Given this list of marker genes PPIF, PDGFA, KRT10, EZR, NPM3, EIF3K (NCBI Gene Id 55373), OASL (NCBI Gene Id 8638), P2RX4, IL1B, NFKB1, PRKRA, ARID5A, HOMER2, CEMIP, CSNK1D, MARCKSL1, MACF1, SLC12A2, CRIP2, CREM, MAPKAPK2, RBM4, SRSF2, VWA8, CRK, PNP, HMOX1, SERPINE1, YWHAZ, TUBB4A, TGFBI, UPP1, EEF1B2, CCL4, LGALS1, DNAJB1, CKS2, UAP1, DUSP5, EMP3, CD69, SEC24D, CD163, IFI44, THBS1, PSMC4, HMGA1 (NCBI Gene Id 3159), PPP1R15A, CLIC1, SRSF3, RPLP0, EIF4E2, CDKN1A, PXDC1, SP100, ZC3HAV1, SLC7A5, HNRNPL, BMPR2, PHLDB1, F13A1, CDC42, IL1RAP, RPN2, CCL3, SLC2A3, SLC16A7, MX1, TP53BP2, HEG1, MXRA7, SSR4, AGO2, MSC, TRAF1, LCP2, LMNA, PTPN2, SRF, IFIT3, NCOR2, COMT, FADS2, MRC1, IVNS1ABP, FUS, PLCG1, PCYT1A, S100A4, SAFB, CDC37, TICAM1, BCAT1, ATF3, DUSP4, ASGR2, TEX30, ICE1, MAP2K3, RGS1, ARNT2, CYP1A1, S100A9, TSC22D3, HINT1, RAB31, USP12, RHOB, SERPINB8, STIP1, CD83, PHLDA2, RPS4Y1, TUBB2A, ICAM1, HSP90AB1, RBMS1, PDE4DIP, ZNF263, NPC1, BCL3, DDIT4, DNM1, ELK4, BTG2, G0S2 (NCBI Gene Id 50486), SERPINB9, SH3BP5, ANPEP, EIF4H (NCBI Gene Id 94573), DEFB1, IL3RA, CXCL2, CXCL1, TNFSF14, ZFP36, CRIP1, POLG, CD99, CD86, CKAP4, RPL35, TXNRD1, ITM2A, XBP1, CLK1, DNAJB5, SP110, CAPN2, CCL7, HNRNPA3, SH3GL1 (NCBI Gene Id 8179), TIPARP, PPP3R1, PIM1, MIR22HG, PRDM1, ATP13A3, S100A8, RUNX3, GDI2, CXCL8, HSPA1A, RPL10A, GEM, TRIM25, LIMK2, CHN2, LAMTOR5, EMP1, CD4, PLTP, FLOT1 (flotillin 1), STAB1, BIN1, MANF, EIF3I, DHX15, SFPQ, EIF4A3, GNA15, P2RY6, SERPINB2, FABP5, RALA, LIMS1, RNF19B, ENG, TNF, CBR3, DUSP2, S100A12, MX2, DUSP1, SLC16A3, ICOSLG, CTNNA1, PLOD3, JUNB, here is a description of the gene set: from publication Suzuki K, Maruya M, Kawamoto S, Sitnik K, Kitamura H, Agace WW, Fagarasan S (PMID 20643338) Germinal centers (GCs) are clusters of activated B cells built on stromal cells known as follicular dendritic cells (FDCs). In the Peyer’s patches (PPs), GCs are chronically induced by bacteria and are the major sites for generation of gut IgA immune responses. Whether FDCs directly contribute to the IgA production in PP GCs is unknown. To investigate the role FDCs in gut immune system, we examined comprehensive gene profiles of FDCs purified from PPs or perypheral lymph nodes (pLNs) with or without immunization. We also tried to reconstitute the PP FDC signature in vitro by pulsed or continuous stimulation of pLN FDCs through TLRs, RARs or simultaneously through TLRs and RARs. studied in species Homo sapiens Human Gene Set: GSE19401_NAIVE_VS_IMMUNIZED_MOUSE_PLN_FOLLICULAR_DC_UP Genes up-regulated in ex vivo follicular dendritic cells from peripheral lymph nodes: naïve versus immunized mice.